The following is a description of a gene set: Genes representing epithelial differentiation module in sputum during asthma exacerbations. species: Homo sapiens from publication Bosco A, Ehteshami S, Stern DA, Martinez FD (PMID 20336062) Asthma exacerbations are associated with subsequent deficits in lung function. Here, we tested the hypothesis that a specific pattern of inflammatory responses during acute exacerbations may be associated with chronic airway obstruction. Gene coexpression networks were characterized in induced sputum obtained during an acute exacerbation, from asthmatic children with or without chronic airflow limitation. The data showed that activation of Th1-like/cytotoxic and interferon signaling pathways during acute exacerbations was decreased in asthmatic children with deficits in baseline lung function. These associations were independent of the identification of picornaviruses in nasal secretions or the use of medications at the time of the exacerbation. Th2-related pathways were also detected in the responses, but variations in these pathways were not related to chronic airways obstruction. Our findings show that decreased activation of Th1-like/cytotoxic and interferon pathways is a hallmark of acute exacerbation responses in asthmatic children with evidence of chronic airways obstruction. Human Gene Set: BOSCO_EPITHELIAL_DIFFERENTIATION_MODULE, and this is the list of marker genes: FBXW10, LCN2, SPRR2A, NDRG2, MAL, PPL, PARD6B, KRT3, IGKC, CEACAM5, ADGRF1, A2ML1, RDH10, F3, TACSTD2, CLCA4, H19, SPRR1B, KRT78, NCCRP1, TGM3, TMPRSS11A, HSPB8, IL36A, IGHD, RHCG, PTPN3, GABRP, EMP2, KRT17 (keratin 17), MUC21, SERPINB2, KRT18, MUC16, TMPRSS11E, DENND2C, KRT4, CEACAM7, ANXA9, SLC6A14, SPNS2, FAM3D, SPRR1A, TRIM16L, PSCA, KRT16 (NCBI Gene Id 3868), TMPRSS2, LMO7, SCEL, TM4SF1, ELF3, TSPAN6, ECM1, GPRC5A, IGHM, TMPRSS11B, TRIM16, DUOX2, IGHA1, MUC4 (mucin 4, cell surface associated), IGLJ3, TMPRSS11D, SPINK5, SPRR3, KRT13, CEACAM6, MUC1, TMPRSS4, CLDN7